Given this list of marker genes CYP27B1, CLCN5, SLC34A3, VDR, CYP2R1, here is a description of the gene set: species: Homo sapiens Human Gene Set: HP_SPARSE_BONE_TRABECULAE Sparse bone trabeculae